The following is a description of a gene set: Human Gene Set: HP_NEOPLASM_OF_THE_PANCREAS Neoplasm of the pancreas species: Homo sapiens A tumor (abnormal growth of tissue) of the pancreas., and this is the list of marker genes: NTHL1, MLH1, POLD1, NHP2, WT1, SPINK1, PRKAR1A, PTEN, NBN, DKC1, RAD51C, TGFBR2, PIK3CA, BRCA2, BAP1, RAD51D, RPS20, GNAS, CCND1, CTC1, CDKN1B, TYMS, MSH2, GCGR, NPM1, BRCA1, COL14A1, CDKN2A, PDGFRB, PDE11A, CHEK2, CLCNKB, CDKN2B, TERC, VHL, STK11, RAD50, PARN, BRIP1, NUTM1, MSH6, CTRC, MITF, PALB2, SMAD4, RTEL1, TINF2, TP53, KRAS, NOTCH3, BARD1, MAFA, MGMT, MUTYH, WRAP53, PMS1, APC, TERT, RNF43, SLC12A3, MC1R, TERF2IP, NOP10, POT1, POLE, ATM, PALLD, RABL3, ACD, MEN1, CDKN1A, EPCAM, KCNJ11, ACVR1B, USB1, CDK4, AAGAB, RAD51, MDM2, SEMA4A, FLI1, EWSR1, PMS2, BMPR1A, BRD4, CDKN2C, MRE11, CDC73